The following is a description of a gene set: Human Gene Set: GOBERT_OLIGODENDROCYTE_DIFFERENTIATION_UP Inadequate remyelination of brain white matter lesions has been associated with a failure of oligodendrocyte precursors to differentiate into mature, myelin-producing cells. In order to better understand which genes play a critical role in oligodendrocyte differentiation, we performed time-dependent, genome-wide gene expression studies of mouse Oli-neu cells as they differentiate into process-forming and myelin basic protein-producing cells, following treatment with three different agents. Our data indicate that different inducers activate distinct pathways that ultimately converge into the completely differentiated state, where regulated gene sets overlap maximally. In order to also gain insight into the functional role of genes that are regulated in this process, we silenced 88 of these genes using small interfering RNA and identified multiple repressors of spontaneous differentiation of Oli-neu, most of which were confirmed in rat primary oligodendrocyte precursors cells. Among these repressors were CNP, a well-known myelin constituent, and three phosphatases, each known to negatively control mitogen-activated protein kinase cascades. We show that a novel inhibitor for one of the identified genes, dual-specificity phosphatase DUSP10/MKP5, was also capable of inducing oligodendrocyte differentiation in primary oligodendrocyte precursors. Oligodendrocytic differentiation feedback loops may therefore yield pharmacological targets to treat disease related to dysfunctional myelin deposition. studied in species Mus musculus Genes up-regulated during later stage of differentiation of Oli-Neu cells (oligodendroglial precursor) in response to PD174265. from publication Gobert RP, Joubert L, Curchod ML, Salvat C, Foucault I, Jorand-Lebrun C, Lamarine M, Peixoto H, Vignaud C, Frémaux C, Jomotte T, Françon B, Alliod C, Bernasconi L, Abderrahim H, Perrin D, Bombrun A, Zanoguera F, Rommel C, Hooft van Huijsduijnen R (PMID 19139271), and this is the list of marker genes: MEF2C, LMNB1, INCENP (NCBI Gene Id 56989), NSL1, SPARC, RDM1, CEP152, CHSY1, ASF1B, NT5DC2, CDH6, PHF1, THYN1, KNTC1, XPO1, NSD2, NET1, ITGB3, CENPN, SNX7, MXD3, KIF22, CSRP2, NUP107, BORA, TBC1D31 (TBC1 domain family member 31), CTC1, FOXM1, MNS1, CENPM, MCMBP, H2AC8, CCDC18, PALB2, MCM6, BIRC5, FANCI, CENPP, USP1, DEPDC1, CENPK (NCBI Gene Id 64105), LRR1, MELK, JPT1, ARHGAP19, UCHL5, RBBP4, AUNIP, POLA1, CPNE8, CYP26B1, TIMELESS, TROAP, MCM5, SPATS2L, KIF20A, ADGRG6, IGF1R, L3MBTL2, SAMHD1, TEDC2, SMC2, PTN, HMGN2, PLEKHO1, FIRRM, SLBP, SPPL2A, RCC1, MIS18BP1, IER5L, RPS6KA6, STAG1, PAFAH1B3, DNAAF2, AKR1E2, ZNF367, ALDH16A1, H1-10, TK1, EXO1, BUB1B, CHEK2, RNF26, SMO, WEE1, CKAP5, AKAP12, CEP70, CDCA4, HDAC4, TPM1, XRCC2, TMEM107, SPC25, RAD51, MAD1L1, WDR76, VARS1, TMEM97, RRP12, VOPP1, FIGNL1 (NCBI Gene Id 63979), RFC4, CCNB1, CACNG4, MREG, HMGB3, RFC5, LPIN2, BRCA2, CCDC34, NEK2, MIS18A, NDC80, RGCC, NASP, DNMT1, LYAR, CLIC1, BEND3, PCLAF, EME1, STIL, HOXA4, NUP210, TRPS1, VCAN, THAP12, BATF3, ID1, OIP5, TEAD1, HAUS5, TCF19, TIPIN, CDC6, EZH2, LIMK1, HJURP, ANKRD24, ERAL1, SLC9A5, MAP3K20, KIAA0586, PKMYT1, UNG, SPRED2, SGO1 (NCBI Gene Id 151648), FRAT1, PBXIP1, SKA1, TTF2, NANOS1, RBL1, PABPC1, CDCA7, ESPL1, CCNF, GAS2L3, NFIB, ARHGAP11A, NDC1, PIF1, LDLR, GEMIN2, TAL1, TEDC1, ADAM23, PMS2, SKA2, SELENOH, TEX30, AURKA, H2AX, RAD50, ERCC6L, CHTF18, RHOT2, ETAA1, CENPW, SLC25A10, CASP3, MCRIP2, TSPAN7, MCM4 (minichromosome maintenance complex component 4), MDC1, PAWR, PRR11, TICRR, SFXN2, DTL, TMEM47, SLC29A2, DCTD, RANGAP1, OSBPL3 (NCBI Gene Id 26031), ATOH8, DDX20 (DEAD-box helicase 20), ZFP41, HIRIP3, FAM111A, ATAD5, AURKB, CDCA5, NOP58, RIF1, DNA2, PASK, NEURL1B, NUP133, GRWD1, DCTPP1, TOP2A, MRNIP, CDC25B, PIMREG, MCM3, CENPI, SIVA1, NKD2, LGR5, NUF2, FBN2, SMPDL3B, NES, DUT, SPC24, KIF23, RFC2, ISY1, MALAT1, DDX11, FBXO5, MTFR2, DLGAP5, NUP85, DLGAP1, AAAS, CIT, C7orf50, SPDL1, ATAD2, TRIM59, CHAF1B, UHRF1, AK4, MYBL2, ANXA2, ROCK1 (Rho associated coiled-coil containing protein kinase 1), KNSTRN, TRAIP, ENKD1, KIF18B, RPA2, MCM7, HAUS3, UBE2C, PTPN6, NUP37, VIM, DNAJC9, RECQL4, GPC6 (NCBI Gene Id 10082), ABCB1, CENPF, ANKRD6, TRMT61A, FAM110A, ANGPTL2, POLD2, E2F7, FSTL1 (follistatin like 1), TONSL, HASPIN (histone H3 associated protein kinase), MTLN, SHMT1, PMF1, NPTXR, LARP7 (La ribonucleoprotein 7, transcriptional regulator), HAUS4, SUV39H2, E2F2, FMC1, ANXA1, C4orf46, PLK4, XRCC1, PLK1, DUSP12, RRM1, PALLD, HROB, FEN1, ORC1, CCND3, UBE2T, HMGN5, NCAPH2, HYLS1, KIF11, HAUS1, PSRC1, FAM234A, ALAD, CENPS, NCAPG, KNL1, GPR19, GINS1, TERF1, STMN1, SKA3, TESC, LANCL2, HMMR, PODXL, HIRA, TAMM41, GEMIN6, IFIT2, FMNL3, PTTG1, UTP25, ARHGEF39, JAK1, STUB1, DEPDC1B, RBMX2, PRC1, MYB, PXYLP1, CCNE2, CCDC61, ZC3H8, KIF18A, CDC20, RAD54L, RFC3, MTSS1, SGO2 (NCBI Gene Id 151246), CBR3, TDP2, FANCD2 (FA complementation group D2), CEP192, CCNE1, PRIM2, CEP55, ZRANB3, LIN54, IQGAP3, PTGES2, NCAPH, CDKN3, KIF4A, LDHB (NCBI Gene Id 3945), KITLG, SUV39H1, HAUS8, PARPBP (NCBI Gene Id 55010), CD38, ZBTB12, NEMP1, MSH6, MYG1, CHEK1, SNX25, ASPM, CCDC77, SALL3, SEPHS1, PA2G4, TAF5, CTDSPL2, ERBB3, MCM2, LSM5, TCOF1, GPR161, WDR62, STAMBPL1, TTLL4, TRIP13, PPARGC1B, PRIM1 (DNA primase subunit 1), TACC3, SHQ1, HMGB2, TMEM109, TAF4, UMPS, CREB5, MAD2L1, CASP7, RSRC2, TBL2, SRGAP2, CAND2, SERPINE2, POLA2, MRE11, FIGN, ECT2, CCNB2, KPNA2, MAP2, AIDA, NUCKS1, GOLT1B, PDLIM1, MLEC, ADGRL2, LASP1, ERI2, ANP32E, TYMS, NCAPD2, POLR1H, CENPA, POLE, VRK1, SRM, ZNF704, PHF19, SPAG5, ARHGAP18, STK17B, DDAH1, SLFN13, KIF2C, NUP54, BLM, GPATCH4, TAF15 (NCBI Gene Id 8148), CENPT, PEG3, KIF20B (NCBI Gene Id 9585), GINS2, CKS2, CKAP2L, CDK2, NUSAP1, DKC1, PTGR1, PIDD1, CENPH, POC1B, CDT1, NOLC1, UPP1, DOCK5, DSCC1, GFOD2, PSMC3IP, KIFC1 (kinesin family member C1), IMPA2, LMNB2, SMC4, CDCA2, FBXL18, LSM2 (NCBI Gene Id 57819), RAD51AP1, NCAPG2, CENPL, HELLS, AEN, NUP43, SKP2, CDK1, TTK, DHFR, RRM2, PDSS1, RBM10, LPCAT4, LIMCH1, GNL1, C1orf159, SLC1A3, CDCA7L, CCNA2, PLAGL1, MMS22L, ZWILCH, BLVRB, PDZRN3, FN1, TGIF2, S100A4, CMC2, DBF4, BOK, NOC2L, RRP1B (ribosomal RNA processing 1B), CENPE, EMP1, ASPH, RACGAP1 (Rac GTPase activating protein 1), KMT5A, PVT1, GTSE1, RFLNB (NCBI Gene Id 359845), FGFR3, CDC7, FAM72A, SASS6, POLR2A, ODC1, SLF1, POLD3, FAM83D, H2AZ1, SNX22, CDC45, MKI67, CKS1B, PBK, PPP2R5C, E2F1, ANKLE1, IFRD2, MDP1, CDCA3 (NCBI Gene Id 83461), CEP131, CDKN2A, CDKN2C, HSPB6, DDIAS, TPX2, DYNLL1, SART3, RPA1, CDCA8, ISOC1 (isochorismatase domain containing 1), GJC3, IFFO2, RC3H2, AARS1, JADE1, CLSPN, CENPQ, MYBL1, NMRAL1, CEP89, ESCO2, MCM8, FANCA, CKAP2, POLE2, PTOV1, GMNN, CCNK, LIN9 (NCBI Gene Id 286826), GEMIN5, HAUS6, NLE1, GAP43, SLC7A2, ANKS1A, SERTAD4, LSM4, RAD18, CDC25C, MCM10, POLD1, CENPU, SHCBP1, WDHD1, BUB1, LIG1, NCL, PPIF, EXOSC8, HAT1, CIP2A